Given this list of marker genes Cxcl10, Ppbp, Ccl28, Cxcl9, Tff2, Pf4, Cxcl12, Cxcl13, Cxcl5, Cxcl11, Itch, Cx3cl1 (C-X3-C motif chemokine ligand 1), Cxcl15, Ccl27a, here is a description of the gene set: Mouse Gene Set: GOMF_CXCR_CHEMOKINE_RECEPTOR_BINDING species: Mus musculus Binding to a chemokine receptor in the CXCR family.